Given this list of marker genes Braf, Carmil1, Myoc, P4hb, Crkl, Flna, C1qbp, Cspg5, Dab2, Enpp2, Myadm, Cdc42, Fermt2, Unc13d, Dnm2, Itgb3, Dbn1, Prex1, Ilk, Nedd9, Rreb1, Lims1, Dock5, Nrp1, Rac1, Abl1, Dock1, Lims2, Cib1, Calr, Has2, Crk, Cass4, Tesk1, S100a10, Rac3, Olfm4, Mdk, Arpc2, Apoa1, Triobp, here is a description of the gene set: Mouse Gene Set: GOBP_POSITIVE_REGULATION_OF_SUBSTRATE_ADHESION_DEPENDENT_CELL_SPREADING Any process that activates or increases the frequency, rate or extent of substrate adhesion-dependent cell spreading. species: Mus musculus